Given this list of marker genes IGKV1D-33, VAV2, FGR, IGKV1-17, NCKAP1, IGLV3-22, IGLC6, WASF1, IGLV3-16, DOCK1, IGKV2D-28, IGKV1-12, IGLV1-47, FCGR3A (NCBI Gene Id 2214), IGLV2-33, IGLV3-1, IGLV7-46, IGKV2-30, ACTG1, WASL, IGKV1D-39, VAV3, YES1, GRB2, ACTR3 (NCBI Gene Id 10096), IGLC1, IGLV2-18, ARPC1A, IGHV4-59, IGKV2-29, MYO10, IGKV1D-16, IGKV1-16, IGKV2-28 (NCBI Gene Id 28921), ARPC3, IGLV4-60, IGLV3-21, IGKV2D-40, IGKC, NCKIPSD, IGHV, IGKV3-15, IGHV1-69, WAS, SRC, IGLV2-8, IGHV3-13, IGKV5-2, MAPK1, FYN, MYH2, IGLC2, BAIAP2, ARPC1B, MYO9B, MYO5A, IGLV3-27, IGLV2-23, ELMO1, IGLV4-3, IGLV2-11, IGLV7-43, IGKV3-20, ABL1, IGHV3-53, CRK, IGLV1-36, IGKV4-1, IGHV2-70, IGLV1-40, WIPF1, CYFIP2, ELMO2, IGHV3-11, LPG1G2, WIPF2, IGLV5-37 (immunoglobulin lambda variable 5-37), ACTR2, MAPK3 (mitogen-activated protein kinase 3), IGLV11-55, IGHV7-81, IGLV8-61, IGKV1-5, IGHG1, IGHV2-5, IGKV3-11, IGLV3-25, IGLV3-12, BTK, IGLV4-69, IGKV1-33, WASF2, ABI2, IGHV1-46, IGHV3-7, ACTB, IGKV1-39, ARPC4, NCKAP1L, IGKV2D-30 (NCBI Gene Id 28881), NCK1, CYFIP1, ARPC2, CD3G, IGHV4-34, IGLC7, SYK, HCK, PTK2, IGHV3-33, IGLV6-57, WIPF3, IGLV10-54, IGLV1-44, ARPC5, IGHV4-39, ABI1, BRK1, MYO1C, IGLV5-45 (immunoglobulin lambda variable 5-45), IGLV2-14, LYN, VAV1, IGKV3D-20, IGHV3-9, IGHG2, IGHV1-2, CD247, IGLV3-19, IGHV3-23, IGHV3-48, IGHG4, IGHG3, IGLC3, CDC42, RAC1, IGHV3-30, IGKV1D-12, WASF3, IGLV, MYH9, IGLV1-51, here is a description of the gene set: species: Homo sapiens Leishmania parasites are dimorphic protozoa, being extracellular and flagellated (promastigotes) in the vector insect, and intracellular and aflagellated (amastigotes) in the host. While the vector fly feeds on the blood of the host, it transmits the promastigotes which are subsequently phagocytosed. The transition to the non motile form occurs within the phagosomal pathway; this process requires the delay of the maturation of the phagosome in such a way that the pH conditions are not harmful to the promastigote. Once it is in the amastigote form, maturation of the parasitophorous vacuole continues (Martínez López et al. 2018). Reactome Pathway: Parasite infection part of: Leishmania infection